The following is a description of a gene set: Mouse Gene Set: GOBP_EPHRIN_RECEPTOR_SIGNALING_PATHWAY The series of molecular signals initiated by ephrin binding to its receptor, and ending with the regulation of a downstream cellular process, e.g. transcription. studied in species Mus musculus, and this is the list of marker genes: Efnb3, Insrr, Sipa1l1, Fgfr3, Pdgfra, Rbpj, Tiam1, Efna2, Ptpn11, Flt4, Mst1r, Epha6, Cdk5r1, Erbb4, Ephb2, Ephb1, Fgfr1, Epha2, Epha3, Efnb1, Efna1, Fgfr2, Ephb6, Tek, Anks1b, Epha1, Diaph1, Ngef (neuronal guanine nucleotide exchange factor), Fgfr4, Tie1, Ddr1, Ptk2, Musk, Epha4 (Eph receptor A4), Egfr, Insr, Alk, Epha5, Flt3, Csf1r, Erbb2, Ret, Tyro3, Crk (v-crk avian sarcoma virus CT10 oncogene homolog), Notch1, Ntrk1, Ss18, Diaph2, Epha7 (Eph receptor A7), Ephb4, Efna5, Pdgfrb, Kdr, Epha8, Ror2, Abl1, Ltk, Igf1r, Ddr2, Efna4, Met, Efna3, Mertk, Axl, Kit, Ros1, Efnb2, Git1, Nck1, Ntrk2 (neurotrophic tyrosine kinase, receptor, type 2), Nck2, Chn1, Flt1, Ephb3, Anks1, Ntrk3, Epha10